Given this list of marker genes H2BC9, H2BC21, MYL12B, RAC1, KLK3, H2BC26, H3C1, KDM4C, KDM1A, H2BC12, PKN1, H2AC20, PPP1R12B, RHOB, SFN, PPP1CB, YWHAB, H2AC6, H2BC3, H4C1, RHOC, MYH9, H2AZ2, H2BC5 (NCBI Gene Id 3017), NCOA2, CDC25C, MYH10, KLK2, H2AC4, H2BC11, YWHAH, H2BC1, YWHAQ, PPP1R14A, YWHAZ, RHOA, YWHAE, PDPK1, H2AC14, PPP1R12A, MYL9, H2AC7, H2AX, H3-3A, H2AC18, H2BC17, PKN3, H2BC15, AR, H2BC14, YWHAG, H2BC12L (H2B clustered histone 12 like), H2BC13, MYH11, PKN2 (NCBI Gene Id 5586), MYH14, MYL6 (NCBI Gene Id 4637), H2AB1, H3C15 (NCBI Gene Id 449003), PAK1, H2AJ, H2BC4, here is a description of the gene set: part of: RHO GTPase Effectors species: Homo sapiens Protein kinases N (PKN), also known as protein kinase C-related kinases (PKR) feature a C-terminal serine/threonine kinase domain and three RHO-binding motifs at the N-terminus. RHO GTPases RHOA, RHOB, RHOC and RAC1 bind PKN1, PKN2 and PKN3, bringing them in proximity to the PIP3-activated co-activator PDPK1 (PDK1). PDPK1 phosphorylates PKNs on a highly conserved threonine residue in the kinase activation loop, which is a prerequisite for PKN activation. Phosphorylation of other residues might also be involved in activation. PKNs are activated by fatty acids like arachidonic acid and phospholipids in vitro, but the in vivo significance of this activation remains unclear.<p>PKNs play important roles in diverse functions, including regulation of cell cycle, receptor trafficking, vesicle transport and apoptosis. PKN is also involved in the ligand-dependent transcriptional activation by the androgen receptor. More than 20 proteins and several peptides have been shown to be phosphorylated by PKN1 and PKN2, including CPI-17, alpha-actinin, adducin, CDC25C, vimentin, TRAF1, CLIP170 and EGFR. There are no known substrates for PKN3. Reactome Pathway: RHO GTPases activate PKNs